Given this list of marker genes MUSK, SNORD115-1, MOG, ZNF365, MKRN3, TNPO3, PDGFB, HMGCL, P2RY11, NUP88, SPIB, CTSH, DHCR7, CLCNKB, TUBA1A, FBP1, MTRR, IL12A (NCBI Gene Id 3592), HERC2 (HECT and RLD domain containing E3 ubiquitin protein ligase 2), DPYS, SMO, LARGE1, MYOD1, GJB1, PRPS1 (NCBI Gene Id 8254), IL12RB1, POMT2, UNC93B1, TWNK, MMEL1, BRAF, NF2, TBK1, SMARCE1, PWRN1, POMT1, TERT, TNFSF4, NPAP1, RAPSN, COA8, PWAR1, TLR3, TRAF3, TICAM1, MAGEL2, SLC12A3, SLC18A3, HLA-DQB1, SMARCB1, PIK3CA, TNFSF15, SLC22A5, SNORD116-1, CNBP, FKTN, TBC1D24 (TBC1 domain family member 24), ASH1L, HCRT, NAA10, IRF5, DOK7, KIF21A (NCBI Gene Id 80819), SLC2A3, CTNNB1, POU2AF1, SUFU, AKT1, FKRP, HMBS, PTS, ACAT1, TRAF7, HLA-DRB1, HTT, DNMT1, BAP1, DMPK (DM1 protein kinase), here is a description of the gene set: studied in species Homo sapiens A state of abnormally strong desire for sleep during the daytime. Human Gene Set: HP_EXCESSIVE_DAYTIME_SOMNOLENCE Excessive daytime somnolence